Given this list of marker genes IER5, MLPH, AREG, MYB, ZNF750, GDF15, CD24P4, RAB11FIP1 (NCBI Gene Id 80223), TM4SF1, TTC39A, LETM1, PDZK1IP1 (NCBI Gene Id 10158), LAMA3, ASNS, PERP, MAGED2, DST, MRPS30, DNAJC12, ACADSB, SCNN1A, FAM234B, OPN3, PEX7, HOOK1, IL20RA, PDCD4, MMP10, DEFB1, ABHD11, MAST4, ABCD3, GALNT7, EPN3, CEBPD, CADPS2, PROM1, ANXA9, PRKAR2B, AUTS2 (activator of transcription and developmental regulator AUTS2), AMY1A, DTNA, ELAPOR1, FAM174B, TBC1D8, CELSR2 (NCBI Gene Id 1952), ERBB4, TBX3, SLC19A2, VAV3 (NCBI Gene Id 10451), ATP6V0A4, CFD, PADI2, CELSR1, SHANK2, SLC1A4, ERBB3, KIAA0040, DSC3, ACTG2, GRAMD1C (GRAM domain containing 1C), TP63, ARHGAP29, MDK, PTPRF, SLC27A2, MYO6, SERPINA1, CD24P2, KRT14, ISOC1, WFS1, TJP3, GPR87, GRB14, CLDN3, PLK2, ALDH3B2, ZDHHC11 (NCBI Gene Id 79844), SORT1, ABAT, LRBA, STC2, TMED5, RAPGEF5, here is a description of the gene set: Becoming invasive is a crucial step in breast cancer oncogenesis. At this point, a lesion carries the potential for spreading and metastasis--a process, whose molecular characteristics still remain poorly understood. In this article, we describe a matched-pair analysis of ductal carcinoma in situ (DCIS) and invasive ductal carcinoma (IDC) of nine breast ductal carcinomas to identify novel molecular markers characterizing the transition from DCIS to IDC. The purpose of this study was to better understand the molecular biology of this transition and to identify candidate genes whose products might serve as prognostic markers and/or as molecular targets for treatment. To obtain cellular-based gene expression profiles from epithelial tumor cells, we combined laser capture microdissection with a T7-based two-round RNA amplification and Affymetrix oligonucleotide microarray analysis. Altogether, a set of 24 tumor samples was analyzed, comprised of nine matched DCIS/IDC and replicate DCIS/IDC preparations from three of the nine tumors. Cluster analysis on expression data shows the robustness and reproducibility of the techniques we established. Using multiple statistical methods, 546 significantly differentially expressed probe sets were identified. Eighteen candidate genes were evaluated by RT-PCR. Examples of genes already known to be associated with breast cancer invasion are BPAG1, LRRC15, MMP11, and PLAU. The expression of BPAG1, DACT1, GREM1, MEF2C, SART2, and TNFAIP6 was localized to epithelial tumor cells by in situ hybridization and/or immunohistochemistry, confirming the accuracy of laser capture microdissection sampling and microarray analysis. species: Homo sapiens Genes down-regulated in invasive ductal carcinoma (IDC) relative to ductal carcinoma in situ (DCIS, non-invasive). Human Gene Set: SCHUETZ_BREAST_CANCER_DUCTAL_INVASIVE_DN from publication Schuetz CS, Bonin M, Clare SE, Nieselt K, Sotlar K, Walter M, Fehm T, Solomayer E, Riess O, Wallwiener D, Kurek R, Neubauer HJ (PMID 16707453)